Given this list of marker genes Gng7, Gnao1, Gng8, Gnb2, Calm1, Gngt2, Ppp3r1, Gng3, Gng4, Wnt11, Fzd2, Pde6g, Plcb3, Gnb5 (guanine nucleotide binding protein (G protein), beta 5), Fzd6, Pde6b, Gng10, Gng11, Tcf7l2, Gngt1, Gng5, Ctnnb1, Fzd4, Nlk, Gnb3, here is a description of the gene set: electronically inferred by orthology from the curated human pathway part of: Beta-catenin independent WNT signaling Reactome Pathway: Ca2+ pathway This event has been computationally inferred from an event that has been demonstrated in another species.<p>The inference is based on the homology mapping from PANTHER. Briefly, reactions for which all involved PhysicalEntities (in input, output and catalyst) have a mapped orthologue/paralogue (for complexes at least 75% of components must have a mapping) are inferred to the other species. species: Mus musculus